Given this list of marker genes BCKDHB, BCAT2, ATP5F1B (NCBI Gene Id 506), BCKDK, MICU1, here is a description of the gene set: Abnormal circulating valine concentration species: Homo sapiens Any deviation from the normal circulation of valine in the blood circulation. Human Gene Set: HP_ABNORMAL_CIRCULATING_VALINE_CONCENTRATION